Given this list of marker genes MAPKAP1, PRKAA2, RICTOR, EIF4EBP1, CDC42, MTOR (mechanistic target of rapamycin kinase), ULK1, IDI1, RRAGD, PRR5, MLST8, PRKCA, PRKAB1 (NCBI Gene Id 5564), RPS6KB1, ULK3, DDIT4, AKT1S1, RPTOR, PRR5L, RRAGB, FKBP1A, RHEB, HMGCR, PRKAA1 (NCBI Gene Id 5562), RRAGC, DDIT4L, PRKAB2, PRKAG2, ULK2, AKT1, RRAGA, PRKAG1, TSC2, RAC1, TSC1, PRKAG3, here is a description of the gene set: Target of rapamycin signaling Human Gene Set: WP_TARGET_OF_RAPAMYCIN_SIGNALING studied in species Homo sapiens